Given this list of marker genes YWHAQ, SMAD2, IGFBP1, FOXO3, GADD45A, BCL6, PCK1, YWHAG, FBXO32, RBL2, YWHAB, SIN3A, SMAD4, SIRT1, SIRT3, ABCA6, PCBP4, BTG1, HDAC2, BCL2L11, AKT2, NFYA, CAT, FOXO6, RETN, HDAC1, NPY, NFYC, FOXG1, CREBBP, SFN, CAV1, MSTN, EP300, G6PC1, ATXN3, TXN, CDKN1A (NCBI Gene Id 1026), TXNIP, CDKN1B, SREBF1, AKT1, PINK1, DDIT3, AKT3, STK11, BBC3, GCK, TRIM63, PLXNA4, SMAD3, NFYB, CCNG2, PPARGC1A, NR3C1, FOXO4, POMC, KLF4, CITED2, YWHAZ, KAT2B, FASLG, SOD2, INS, AGRP, FOXO1, here is a description of the gene set: The family of FOXO transcription factors includes FOXO1, FOXO3, FOXO4 and FOXO6. FOXO transcription factors integrate pathways that regulate cell survival, growth, differentiation and metabolism in response to environmental changes, such as growth factor deprivation, starvation and oxidative stress. Reactome Pathway: FOXO-mediated transcription species: Homo sapiens part of: Generic Transcription Pathway